The following is a description of a gene set: Immune cell-specific expression is one indication of the importance of a gene's role in the immune response. In order to identify such patterns, we set out to broadly profile gene expression in a variety of immune cells. Genes up-regulated in comparison of naive B cells versus unstimulated neutrophils. studied in species Homo sapiens from publication Abbas AR, Baldwin D, Ma Y, Ouyang W, Gurney A, Martin F, Fong S, van Lookeren Campagne M, Godowski P, Williams PM, Chan AC, Clark HF (PMID 15789058) Human Gene Set: GSE22886_NAIVE_BCELL_VS_NEUTROPHIL_UP, and this is the list of marker genes: ESD, RPS27A, LBH, RPL11, HMGN3, RRAS2, ZNF22, SIDT1, BCL7A, SEPTIN6, ODC1, RPL6, HLA-F-AS1, TSPAN13, PDLIM1, EEF2, BCL11A, SRSF7, HLA-DRA, RPL35, P2RX5, HLA-DOB, RPL23 (ribosomal protein L23), RPS24, APPL1, RPS17, TTC31, RPL39, TRMT11, RPS6, RUBCN, IGHD (immunoglobulin heavy constant delta), IGHM, TPD52, TEX10, RPS27, RPL37A (ribosomal protein L37a), ACAT1, HNRNPA1, RPL27A, PKIG, DDR1, SZT2, SYNE3, DNPEP, MPHOSPH9, PSMD14, JUN, RACK1, NEK9, WDR6, DDHD2, SETBP1, BANK1, NMD3, SP140L, POU2AF1, CROCCP2, RPS5, IRF4, RPS7, NPIPA1, UBE3A, HLA-DRB1, HLA-DRB6, RPL7A, HSP90AB1, GABBR1, PKIA, RPL30, ITPR1, CD19, MDFIC, RPS14, MALT1, FBXO21, EVL, RPL36A, DDX39A, BACH2, CD81, RPL41, SF3A3 (NCBI Gene Id 10946), EZR, UPF3A, BLNK, PARP1, DLG1, RPS20, RPL9, MDH1, RPL38, GSAP, EIF3L, CD83, ST6GAL1, TSC1, NR3C2, CD74, RPL35A (ribosomal protein L35a), HLA-DPA1, DNAJC16, HLA-DQB1, IRF8, RPL10, PKD1P1, GOLGA8B, TMEM156, SPIB, RPL27, TCF4, CD72, DKC1, COMMD3, MCM2, SUMO3, PLAC8, RFTN1, TIMELESS, MAP3K4, NCL, RBM38, FAM30A, NPM1, CD200, CD22, TMSB10 (NCBI Gene Id 9168), CD79A, OPN3, R3HDM1, CD69, RPL37, CD79B, NAP1L1, RPL8, VPREB3, CYP20A1, RPS11, SLC25A6, RPL34, STAP1, CHD1L, RPS18, TSPYL4, AKAP11, MRPS35, HLA-DPB1, USP9Y, LY86, RIOX1, HLA-DMB, FBXO42, MDN1, RPS13, RPS25, POLE3 (NCBI Gene Id 54107), RPL26, ARID5B, GPR18, RPL21, FCMR, SMAD3, RPS19, CRTC3, RPS15, TRAF5, EIF4A2, CD52, PHLPP2, MCUB, EBAG9, RPL28, SERPINB9, FCRL2, TRIB2, RPLP1, ZBTB40, RXYLT1, PDHX, CR2, PLCXD1 (phosphatidylinositol specific phospholipase C X domain containing 1), DCAF17, TTC3, IGKC, TCL1A, MUTYH, ATXN10, PIK3C2B, LRPPRC, RPS16, SLC35F2, ZNF571 (NCBI Gene Id 55594), SOBP, AKAP1, GLO1, RPL15, HYOU1, GARRE1, PRPS1